Given this list of marker genes BMPR1A, CREBBP, PIGQ, GRM7, GPC4, PNKP, ABCC9, CASK, SCN1B, SCN2A, ARX, KCNJ8, CDKL5, BMP2, PTEN, GNAO1, MED25, WDR19, NEUROD2, TRIM8, HOXD13, NXN, GRIN1, EP300 (E1A binding protein p300), SLC32A1, FGFR1, GATA4, DMXL2, GLI3, SUMF1, SIK1, FGFR2, FLI1, EFNB1, SLC25A22, DACT1, HS2ST1, SALL4, CTCF, SALL1, PIGP, ROR2, KCNA1, SATB2, here is a description of the gene set: Broad phalanx of the toes Increased width of phalanx of one or more toes. Human Gene Set: HP_BROAD_PHALANX_OF_THE_TOES studied in species Homo sapiens